The following is a description of a gene set: species: Mus musculus Catalysis of the rearrangement of both intrachain and interchain disulfide bonds in proteins. Mouse Gene Set: GOMF_PROTEIN_DISULFIDE_ISOMERASE_ACTIVITY, and this is the list of marker genes: Creld1, Pdia6, Tmx1, Qsox2, Pdia4, Tmx3, Erp27, Pdilt (NCBI Gene Id 71830), Enox1, Pdia5, P4hb, Itgb3, Qsox1, Txndc5, Creld2, Erp44, Pdia3, Pdia2, Txndc2